Given this list of marker genes CNN1, ZNF516, DENND2B, SGCE, BTG3, DAAM2, CYLD, SEC23A, LPIN1, TGFB1I1, TPM2, TACC1, RBPMS, MEIS1, MEIS2, ATP2B4 (NCBI Gene Id 54594), LAMA4 (NCBI Gene Id 3910), PPP1R12B, C7, GATM, GAS1, SCRN1, HMGN4 (high mobility group nucleosomal binding domain 4), PCP4, PMP22, MYLK, DST, CLU, AKAP12, CAVIN1, GSN, VCL, FHL1, SPART, CALM1 (calmodulin 1), SMTN, LGALS3, MYOF, ITGB4, SVIL, here is a description of the gene set: Genes down-regulated in prostate cancer vs benign prostate tissue, based on a meta-analysis of five gene expression profiling studies. from publication Tomlins SA, Mehra R, Rhodes DR, Cao X, Wang L, Dhanasekaran SM, Kalyana-Sundaram S, Wei JT, Rubin MA, Pienta KJ, Shah RB, Chinnaiyan AM (PMID 17173048) species: Homo sapiens Human Gene Set: TOMLINS_PROSTATE_CANCER_DN Despite efforts to profile prostate cancer, the genetic alterations and biological processes that correlate with the observed histological progression are unclear. Using laser-capture microdissection to isolate 101 cell populations, we have profiled prostate cancer progression from benign epithelium to metastatic disease. By analyzing expression signatures in the context of over 14,000 'molecular concepts', or sets of biologically connected genes, we generated an integrative model of progression. Molecular concepts that demarcate critical transitions in progression include protein biosynthesis, E26 transformation-specific (ETS) family transcriptional targets, androgen signaling and cell proliferation. Of note, relative to low-grade prostate cancer (Gleason pattern 3), high-grade cancer (Gleason pattern 4) shows an attenuated androgen signaling signature, similar to metastatic prostate cancer, which may reflect dedifferentiation and explain the clinical association of grade with prognosis. Taken together, these data show that analyzing gene expression signatures in the context of a compendium of molecular concepts is useful in understanding cancer biology.